The following is a description of a gene set: Genes having at least one occurrence of the motif SNWTTCNN in the regions spanning 4 kb centered on their transcription starting sites. This matches the STAT4 transcription factor binding site V$STAT4_01 (v7.4 TRANSFAC). studied in species Homo sapiens Human Gene Set: STAT4_01, and this is the list of marker genes: NOTCH4, IGF1, ITGA8, DOK3, RNF138, TLL1, MRPL24, KCNK10, CITED2, TOM1L1, FGF8, ERF, APPL2, CLEC1A, EML4, PRDM10, HSD11B1, PRCC, STAT5A, RHOQ, SLC26A3, NFAT5, SOSTDC1, MSL2, EGF, CRYGB, PDE4D, POLR1D, GREM1, PITX2, CABCOCO1, HTR3B, TFAP4, ZNF485, ANKRD28, PTCHD4, SDCBP, NKAPD1, ARPC2, CPA3, RIN2, MRGPRX2, RASSF8, SH2B3, PRKCH, ACBD6, MITF, RHOJ (ras homolog family member J), OSR1, SMOX, HOXC6, CXXC4, LRRC32, BDNF, CD3D (CD3 delta subunit of T-cell receptor complex), FAM24B, PHF21A, CA3, GRIA1, AFAP1, HNRNPD, PTK7, OPRM1 (NCBI Gene Id 4988), SAP130, DOCK4, WBP1L, FYTTD1 (NCBI Gene Id 84248), LINC03122, PAX8 (paired box 8), CIMAP1C, ALPK2, ETS1, TCF15, CSPG4, MBNL1, MTF2, LNX2, USP2, TMEM59L, ERG, CACNA1E, SGK1, NUDT4, IKZF4, TNFRSF19, SMAP2, SESTD1, LPL, SHOX2, HOXB9, EVA1C, EIF1, OSGEPL1, TMPRSS11D, TSEN54, YARS1, TBC1D17, STX19, HIPK3 (NCBI Gene Id 10114), PSME3IP1, PIH1D2, NSG2, JMJD1C, TRPC4AP, CLOCK, ERG28, FLT1, POU4F1, CCDC91, FEV (NCBI Gene Id 54738), ADNP, IL21, ARL4C, TRERF1, CREBZF, TTYH2, CALY, MAP4K2, NEDD4 (NEDD4 E3 ubiquitin protein ligase), FAM81A, HSPB7, RNF43, PRR5L, STMN2, POU3F3, SATB1, ABCB1, CARMIL1, BLNK, MPO, RUNX2, SLC36A2, MTUS1, UBL3, ENSG00000228919, TRIM62, CBLIF, LIMK2, ANGPTL1, TAPBPL, SLMAP, MLXIP, GRHL3, BMP5, ZEB2, CTNNB1, HOXD10, GSC, EDN1, BCL6B, HOXB4 (homeobox B4), NRG1, UBE2D3, TDRD9, ADAP1, EXTL2, HHEX (NCBI Gene Id 5556), FGF12, PBK, FEZ2, JADE2, HOXB3, CHD6, VAV3, PRKCB, ARRDC3, EPM2A, LINC00314, LINC01931 (long intergenic non-protein coding RNA 1931), SLC38A2, FN1, P2RY13, PDE6D, HOXD8, PIK3C2G, FAM20A, FSIP2, FGF10, CPEB4, FLI1, CACNG3, LDHAL6B, MEF2C, ZNF385B, CA14, MYL3, GPHN, CSF3R, VSNL1, FOXG1, STAB1, RUNX3, GNB2, GRIN2B, AAR2, RBMS1, GPX1 (NCBI Gene Id 2876), NPNT, HNF4G, ZBTB37, KY, LRIT3, MAPK10, BZW1, RHBDL3, CTSK, MIDEAS, NMNAT3, PCDH1, NR4A1, AKT1S1, GNL3LP1, VIT, PHOX2B, ABRAXAS2, AP1G2, FEM1C, PDLIM2, SPEM1, NRAS, CISH, PBX1, KRT73, CSRP3, CMYA5, CALR, TMC3, LGI1, GRID2, TWIST1, AAK1 (NCBI Gene Id 652453), ZDHHC8, YIPF3, PKP4, NCAM1, RBFOX1, LEPROTL1, EMC3, LAT, DHH, LETM2, ST8SIA1, RAB1B, CD200R1, STIM2, CASKIN2, NEXN, AP4E1, HOXC13, FANK1, ACTN1, PITPNC1, SLF2, NDFIP1, GPRC5D, RSPRY1, CCDC148, S1PR2, SOHLH2, SETD2, PDZD2 (NCBI Gene Id 23037), PHTF1, PPARGC1A, TSHZ2, MECOM, ECHDC2, TNKS1BP1, MAP2K7